Given this list of marker genes CFAP410, VCP (valosin containing protein), ATXN2 (ataxin 2), ERBB4, SOD1, OPTN, FGFR3, TP63, PON2, CCR6, PRPH, GLT8D1, ANXA11, PON3, NEK1, FIG4, CAV1, PFN1, MAGEL2, UNC13A, CCN2, MATR3, NOD2, SLC12A2, IRF5, CLDN10 (NCBI Gene Id 9071), FUS, CCNF, DCTN1, LBR, ELOVL1, FGFR2, SCN9A, TAF15, GSN, PPARGC1A, SQSTM1, CHRM3, NEFH, FGF10, UBQLN2, VAPB, EDARADD, PON1, CHMP2B, GLE1, SIM1, ANG, HLA-DRB1, TBK1, TREM2, TARDBP, HNRNPA1, DAO, CHCHD10, here is a description of the gene set: Dryness of the mouth due to salivary gland dysfunction. species: Homo sapiens Xerostomia Human Gene Set: HP_XEROSTOMIA